Given this list of marker genes IL2RG, CCL22, LAMP3, SAMD9L, NR6A1, DUSP5 (NCBI Gene Id 1847), ARHGAP10, CCL17, GPR132, GTDC1 (glycosyltransferase like domain containing 1), PTPRK, CCR7, TNIP2, SLC25A25, VCAM1, POGLUT1, MROCKI, RNF144B, APOL3, ST20, ORAI2, SNN, HLA-DOB, ETV3, HLA-DQB2, CHST7, SDC2, CD58, EPHB3, STARD10, SH2B2 (SH2B adaptor protein 2), TCHH, GMPPB, CCDC28B, CD1C (CD1c molecule), NECTIN2, ARHGAP22, CDC42EP1, ISG20 (NCBI Gene Id 3669), HIVEP2, ARHGAP31, CST7, RFTN1, NPIPA1, CD1E, CXCL9, MT2A, TVP23A, MCOLN2 (mucolipin TRP cation channel 2), HIVEP1, IDO1, ZEB1, CREB3, EBI3, GBP2, CD207, SLC38A1, BIRC3, HYOU1, TRAF1, MAP3K14, GBP4, GADD45A, HLA-F, GPR137B, IL4I1, GBP1, ADAM8, TRAF2, CCL19, CD80, NET1, TRIP10, PARM1, EGLN2, HES4, VMO1, CD40, USP12, PPAT, MTNAP1, ALCAM, SGTB, PXDC1, DNASE1L3, SLC9A1, ZBTB46, ETV3L, ST3GAL2, MIR155HG, TMEM156, TUBB6, TIFAB, PLA1A, GBP3, NAA30, CD274, IL7R, CXCL10, C15orf48, TNFRSF18, UAP1, NIBAN1, here is a description of the gene set: species: Homo sapiens from publication He P, Lim K, Sun D, Pett JP, Jeng Q, Polanski K, Dong Z, Bolt L, Richardson L, Mamanova L, Dabrowska M, Wilbrey-Clark A, Madissoon E, Tuong ZK, Dann E, Suo C, Goh I, Yoshida M, Nikolić MZ, Janes SM, He X, Barker RA, Teichmann SA, Marioni JC, Meyer KB, Rawlins EL (PMID 36493756) aDC 2 Human Gene Set: HE_LIM_SUN_FETAL_LUNG_C2_ADC_2_CELL